The following is a description of a gene set: Reactome Pathway: RNA Polymerase II Promoter Escape This event has been computationally inferred from an event that has been demonstrated in another species.<p>The inference is based on the homology mapping from PANTHER. Briefly, reactions for which all involved PhysicalEntities (in input, output and catalyst) have a mapped orthologue/paralogue (for complexes at least 75% of components must have a mapping) are inferred to the other species. electronically inferred by orthology from the curated human pathway studied in species Mus musculus part of: RNA Polymerase II Transcription Initiation And Promoter Clearance, and this is the list of marker genes: Taf7, Taf9b, Gtf2h2, Taf6, Taf4b, Taf10, Polr2c, Taf7l, Polr2e, Taf12, Gtf2h4, Gtf2a1, Ercc3, Polr2b, Ccnh, Gtf2b, Taf1, Taf11, Taf5, Gtf2f1, Polr2l, Gtf2e2, Polr2i, Polr2f, Taf8, Taf13, Gtf2e1, Taf15, Polr2k, Gtf2f2, Polr2a, Ercc2, Tbp